Given this list of marker genes ATP6V1G1, MT1X, NMRAL2P, CDC42EP3, ATP2B1-AS1, DUSP1, FERMT2, PHACTR1, GEM, ACSL3, RAB1A, LINC-PINT, LRFN4, PTGS2, MELTF, MMP19, CKS2, M6PR, IL1R1, ETS2, GPCPD1, SH3BP5, NAB2, SNAPC1, FOSL1, SPAG5, SGMS2, NSMAF, SPP1, CEBPB, KLHL6 (kelch like family member 6), UAP1, ABL2, TBC1D7, RHEB, PPARG, LONRF3, CRADD, LY9, DYRK3, KLHL21, CCL20, SPINK1, RIOX1, MT1H, JUN (NCBI Gene Id 3725), GLA, PPFIA1, EGLN3, CCRL2, CXCL3, STX4, DNAJB5 (NCBI Gene Id 25822), FABP5, BCAR3, CSF1, EGR2, COL15A1, UPP1, AKIRIN2, RABGEF1 (RAB guanine nucleotide exchange factor 1), CDKN1A, CTSV, CHSY1, ST3GAL6, MGAM, RRAD, ZSCAN5A, RAB20, PNP, EIF4A1, UBASH3B, SLC38A2 (solute carrier family 38 member 2), TMEM70, NPC1, EIF2AK3, IARS1 (isoleucyl-tRNA synthetase 1), KCTD7, BAG3, IL1RL2, KLF10, LBX2-AS1, CXCL8, MAPK6, CXCL2, STARD8, LYSET, MMP1, DTL, SLC17A5, GARS1, EIF4E, TUBB6, TXNRD1, NEU1, ZBTB21, RAB7B, RIT1, S1PR3, ASPH, TXN, SLC26A2 (NCBI Gene Id 1836), MOAP1, GNA13, P2RX4, ANKRD28, EDN1, HECW2, SLCO4A1, TLNRD1, SNUPN (NCBI Gene Id 10073), TARS1, SLC3A2, CCL7, P2RY1, OLIG2, RGS1, GNPDA1, ETF1, USP53, ESYT2, TCEAL9, PRXL2C, ZNF674-AS1, MT1G, TNFSF15 (NCBI Gene Id 9966), TMEM217, DUSP14, ZBTB43, SESN2, SMIM13, NRIP3, LINC00847, DUSP4, NEDD4L, TMEM38B, CHAC1, CORO1C, MIR22HG, HAVCR2 (hepatitis A virus cellular receptor 2), INSIG1, ADNP2, HSPA9, CCNA1, RASGEF1B, CTSLP8, PRKAG2, DCSTAMP, HOMER1, MT1F, SGK1, FNDC3A, TAF9, TNFSF14, MT1E, TRIB1, ADO, DUSP5, DAB2, KDM7A-DT, DUSP3, PLCXD1, CRTAM, SCML1, SNX9, NAA50, TBC1D2, NRARP, DYNLT2B, JMJD1C, LRRC8B (NCBI Gene Id 23507), CSRNP1, B3GNT5, CSTB, SRXN1, HIC1, RRAGD (Ras related GTP binding D), LPL, ZFYVE16, F3, E2F6, INHBA, MAP4K3, SPAG9, CTSL, LINC01010, ZC3HC1, GFOD1, FNIP2, PLPP3, GPRC5A, RNF19A, VPS37B, KBTBD8, here is a description of the gene set: Genes up-regulated in comparison of monocytes treated with anti-TREM1 versus untreated monocytes. Human Gene Set: GSE9988_ANTI_TREM1_VS_VEHICLE_TREATED_MONOCYTES_UP TREM-1 is an orphan immunoreceptor expressed on monocytes, macrophages, and neutrophils. TREM-1 associates with and signals via the adapter protein DAP12/TYROBP, which contains an immunoreceptor tyrosine-based activation motif (ITAM). TREM-1 activation by receptor cross-linking is pro-inflammatory, and can amplify cellular responses to Toll-like receptor (TLR) ligands such as bacterial lipopolysaccharide (LPS). To investigate the cellular consequences of TREM-1 activation, we have characterized global gene expression changes in human monocytes in response to TREM-1 cross-linking in comparison to and combined with LPS. Both TREM-1 activation and LPS up-regulate chemokines, cytokines, matrix metalloproteases, and PTGS/COX2, consistent with a core inflammatory response. However, other immunomodulatory factors are selectively induced, including SPP1 and CSF1 (i.e., M-CSF) by TREM-1 activation and IL-23 and CSF3 (i.e., G-CSF) by LPS. Additionally, cross-talk between TREM-1 activation and LPS occurs on multiple levels. While synergy in GM-CSF protein production is reflected in commensurate mRNA abundance, comparable synergy in IL-1b protein production is not. TREM-1 activation also attenuates the induction of some LPS target genes, including those that encode IL-12 cytokine family subunits. Whereas positive TREM-1 outputs are abolished by the PI3K inhibitor wortmannin, this attenuation is largely PI3K-independent. These experiments provide a detailed analysis of the cellular consequences of TREM-1 activation, and highlight some of the complexity in signal integration between ITAM- and TLR-mediated signaling. from publication Dower K, Ellis DK, Saraf K, Jelinsky SA, Lin LL (PMID 18292579) species: Homo sapiens